Given this list of marker genes MEX3C, DCLK1, PDSS1, SH3GL1, PPP2R5B, RSPO4, GALNS (galactosamine (N-acetyl)-6-sulfatase), GART, here is a description of the gene set: Human Gene Set: MIR4649_5P species: Homo sapiens from publication Chen Y, Wang X (PMID 31504780) Genes predicted to be targets of miRBase v22 microRNA hsa-miR-4649-5p in miRDB v6.0 with MirTarget v4 prediction scores > 80 (high confidence targets).